The following is a description of a gene set: Human Gene Set: GOMF_NUCLEAR_IMPORT_SIGNAL_RECEPTOR_ACTIVITY Combining with a nuclear import signal (NIS) on a cargo to be transported, to mediate transport of the cargo through the nuclear pore, from the cytoplasm to the nuclear lumen. The cargo can be either a RNA or a protein. species: Homo sapiens, and this is the list of marker genes: KPNA6, KPNA4, IPO5, SNUPN, RANBP6, TNPO2, KPNA3, IPO4, HIKESHI, KPNA7, IPO9, KPNA5, NUTF2, IPO11, TMCO6, KPNA1, TNPO1, KPNA2, TNPO3, KPNB1